The following is a description of a gene set: Human Gene Set: WP_MIRTARGETED_GENES_IN_LYMPHOCYTES species: Homo sapiens miR-targeted genes in lymphocytes, and this is the list of marker genes: CYP1B1, ABHD10, TGFBR2, AKAP8, RAI14, MIR26B, MYB, HMOX1, TNFRSF10B, WNT5A, KRAS, FNDC3A, CDKN1C, SRPRB, SLC12A4, LMNB2, MIR140, ATP6V1C1, PPP1R7, NAA15, DNMT3B, ARID1A, SNAP23, MIR106B, SLC25A13, ABCF2, HMGA1, SCYL1, NCEH1, E2F1, ATG3, MIR23B, UBE2S, VEZT, CDK5RAP1, NT5C3A, SLC1A4, MIR30A, MIR103A1, PLXND1, RFT1, GNL3L, MIR15B, GNA13, MIR370, TBCA, MIR130A, SHOC2, MIR148A, SEC24A, MIR127, TUSC2, PWP1, MYO1E, POM121, MIR196B, UAP1, PRIM1, TRAM1, DNMT3A, NRP1, ANAPC1, PHC2, SLC38A2, SLC7A6, MYCN, VPS39, GAK, MIR138-1, GFM1, GRPEL2, MAPK7, CEP72, IDH1, PAFAH1B2, RAB23, DOCK7, MAGT1, RBM19, MIR124-3, CDKN1A, UBE4A, POGLUT3, ELMOD2, MIR20A, NXN, RRP8, FRG1, BDNF, TMEM59, FMNL2, GALNT7, PGM1 (phosphoglucomutase 1), MIR181B1, EGFR, RHOB, TTC9C, MIRLET7B, TERT, CNOT9, NARS1, TPPP3, VTI1B, MAT2A, MRC2, EIF4E, CSDE1, MIR223, CLDN1, ATP6V1F, ANKFY1, THEM4, CCND1, PKN2, G6PD, PEDS1-UBE2V1, SLC38A1, RBMS1, LTN1, MIR21, MIR26A1, PDLIM7, TRPV6, SYPL1, GAS2L1, CDK5RAP3, P4HA2, UTP15, TAF9B, MIR181D, MIR378A, MYLIP, USP1, MPZL1, TNFAIP2, COMMD9, MIR148B, ADPGK, SPCS3, ITGA2, HDAC4, OTULINL, MIR199A1 (microRNA 199a-1), ATP6V0A1, DDX5, MIR133A1, SFXN1, MIR129-2, PTPRJ, MIR29C, CPOX, MIR155, CTSC, LAMTOR3, KIT, RAB6A, CHMP2A, SUCLG2, ACAA2, BRPF3, TM6SF1, MSI2, LAMTOR5, NCL, DHX40, GPAM, AMIGO2, CD164, TP53INP1, AP2A1, MEOX2, MRPS33, KCNN4, MAPK14, SEC23A (SEC23 homolog A, COPII coat complex component), IQGAP3, DNAJB1, RDH10, MRPL20, MIR17, WDR82, PTGES3L-AARSD1, NCOA3, CHD1, STX7, MIR372, MIR129-1, RHEB, TRMT1, BCL2, IGF2BP1, EZH2, AGO3, PTPRF, RAB27B, PDE3A, NUCB1, PPP5C, RARS1, SLC4A10 (solute carrier family 4 member 10), DOCK5, GPD2, MIR26A2, SSNA1, SLC4A7, PURA, MIR181B2, CAPG (capping actin protein, gelsolin like), PKM, CEBPB, KCNQ1, RCOR1, ABCG2, HNRNPM, TXN2, GFPT1, CPNE8, LAMC2, SCAMP1, SLC12A2, SNAP29, MRM1, PPIF, MIRLET7A1, SEC62, NAPG, TRIP13, MIR199B, BCKDHB, ATP2A2, MIR141, TMT1A, MIR1-1, MIR138-2, VAMP3, ATRX, CHAF1A, RB1, CDKAL1, ADIPOR2, SYNE2, LUZP1, TMED3, AXL, CCN1, MTPN, ASH2L, BACE1, ATG9A, PRKCI, TUBA1A, COIL, MTHFD2, ELOVL5, MIR107, TMEM43, WDFY1, CDK6, HACD3, CARHSP1, RAD23B, SPRYD4, SYNE1, MIR101-1, RCN2, YWHAQ, SH3BGRL3, CDKN2A, ARID4B, PPP2R5C, POLR2C, SMAD1, SRSF10, MCL1, FXR2, MIR200A, TPM2, RTN4 (reticulon 4), CXCL12, PANX1, TPM4, NPR3, GALNT1, BACH1, NELFCD, FGF2, SERP1, TNFRSF10A, FERMT2, MIR520H, TPM3 (NCBI Gene Id 91191), HSDL1, MIR181A1, ANXA2, MARS2, ARL10, POLA2, GYS1, PLAG1, ARFIP1 (ADP ribosylation factor interacting protein 1), C1orf56, MIR145, SDCBP (NCBI Gene Id 6386), PXDN, DMTF1, HARS1, ZNF622 (zinc finger protein 622), EHMT2, UNC93B1, FNDC3B, CDCP1, CYP51A1, NT5E, MOV10, MIR181A2, MIR222, SLC25A24, CLOCK, SLC25A1, BET1, MIR29B2, SH3BP4, NOTCH1, PDLIM5, MIR143, CBFB, PPP3R1, TMED7, PTRH1, ARHGDIA, MIR3074, MET, MIR196A1, AP3D1, MIR16-1, FADS1, LAMC1, WDR11, RAB34 (NCBI Gene Id 83871), PSAT1, PTBP1, TNFSF9, AP3B1, SAC3D1, PISD, FAR1, TMEM41B, RAB5C, TCL1A (NCBI Gene Id 8115), RAVER2, BCL6, MIR200C, PTBP2, NOTCH2, CORO1C, MIR133A2, CACNA2D1, MIR23A, TDG, MIR126, CALCOCO2, VCAM1, CAP1, HSD17B12, IFRD1, SMC1A, DCAF7, ATAT1, PPP3CA, MBNL1, IPO4, CAND1, PRPF40A, MIR150, MAP3K8, GNAI2, MIRLET7E, NHERF2 (NHERF family PDZ scaffold protein 2), MTRR, IRS1, ADAMTSL4-AS1, MAPK12 (mitogen-activated protein kinase 12), MIR200B, LRRC8A, ATAD3B, MATR3, CDIPT, POLD2, MIR124-2, MTX1, MIRLET7G, MIR196A2, CSRP1, MIR199A2, TMED2, PNP, CUL4B, MIR29B1, SNX15, CIAO2A, UHRF1, ACP2, CTNNB1, MIR133B, GOLGA7, MIR181C, COL4A2, GEMIN7, AURKB, KPNA3, LCLAT1, MRPS24, FADS2, MIR20B, MIR16-2, PPIB, SRSF9, LPL, MPDU1, NEDD4, GNPNAT1, MIR221, NF2, POLE4, MIR9-1, ARFIP2, ARID2, SPTLC1, ANP32B, NUFIP2, CDKN1B, PTMA, PDCD4, GSTM4, SLC25A32, NFIA, MIR101-2, SLC25A22, DHX57, ZEB1, PLK1, BRI3BP, HIPK3, CHORDC1, YIF1B, TMED10, FBXW11, CSNK1D, MYO10, MIR34A, IGF2R, HOXA5, RHOG, SERPINE2, UBE2J1, MIR3591, DHX15, ATP6V0E1, HOXD8, MIR375, PTPA, LY6K, TXNRD1, EHMT1, MIR92A2, GEMIN2, TYMS, ADAR, PGRMC1, PICALM, SNX6, E2F3, GTPBP3 (NCBI Gene Id 84705), ANPEP, ARCN1 (NCBI Gene Id 372), ARF4, RAB30 (NCBI Gene Id 27314), MIRLET7A2, TMEM109, TPM1, STRN, C1QBP, SIGMAR1, ABHD11